Given this list of marker genes GALNT13, CSGALNACT2, GALNT16, GALNT18, GALNT6, CHPF (NCBI Gene Id 79586), B4GALNT2, GALNT15, GALNT7, B3GALNT2, GALNT11, EXTL2, B4GALNT4, B3GALNT1, GALNT10, GALNT17, B4GALNT3, GALNT5, GALNT2, CHSY1, GALNT3, GBGT1, CHSY3, GALNT14, ABO, GALNTL6, CSGALNACT1, GALNT12, B4GALNT1, CHPF2, GALNT4, GALNT1, GALNT9, GALNT8, here is a description of the gene set: Catalysis of the transfer of an N-acetylgalactosaminyl residue from UDP-N-acetyl-galactosamine to an oligosaccharide. Human Gene Set: GOMF_ACETYLGALACTOSAMINYLTRANSFERASE_ACTIVITY species: Homo sapiens